The following is a description of a gene set: studied in species Mus musculus from publication Yevshin I, Sharipov R, Kolmykov S, Kondrakhin Y, Kolpakov F (PMID 30445619) Genes containing one or more binding sites for (Myb) in their promoter regions (TSS -1000,+100 bp) as identified by GTRD version 20.06 ChIP-seq harmonization. Mouse Gene Set: MYB_TARGET_GENES, and this is the list of marker genes: Ccdc15, Smarcc2, Cc2d1a, Usp11, Usp36, Arf6, Septin9, P2rx4, Tspo2, Asphd1, B230369F24Rik, Epb41l4aos, Rbfox2, U2surp, Katnal1, Cdc123, Atp2b4, Tax1bp1, Nelfa, Depdc1b, Trem1, Yif1b, Pigc, Rhobtb1, Tmem143, Eri3, Cep83os, Yars1, Gm15518, Wdfy2, Heg1, 4933406C10Rik, Cep70, Tmem33, Mblac1, B4galnt1, Tnfaip6 (tumor necrosis factor alpha induced protein 6), Sae1, Mrps23, Sf3a3, Taf5l, Gm22353, Il3ra, D030047H15Rik, Aldh6a1, Cacna1c, Rrm1, Kcnq1, Cep97, Pdcd5, 1700034P13Rik, Ifitm7, Cct8, Ambra1, Lrrc40, Cd69, Snord15a, Dhrs7b, Gnaq, Eprs1, Cspp1, Sema6b, Rbp2, Tti2, Zfp87, Mutyh, Cmtr1, Ep400, Cebpa, Psmb3, Raf1, Ptgs1, Gm25408, Ubn2, Slc35e1 (NCBI Gene Id 270066), Cdan1, Anapc10, Psma6, Emc3, Gm15581, Sms, Mllt3, Syngr4, Gm11532, Nme7, Map2k5, Tbl3, Abcf2, Nol8, Pex12, Golt1b, Clcn3, Gm8197, Toe1, Zfp35, Prps1l1, Pigv, Sh3gl1, Slc28a2, Pip4k2a, Tubgcp6 (NCBI Gene Id 328580), Acsl6, Fam117a, Gm16023, Tardbp, Tesmin, Znrf1, Hexim1, Rfx2, Cnot1, Tbl1xr1, Nab2, Treml4, Wdr7, Borcs8, 4833445I07Rik, Hes6, Tspyl3, Gm28857, Gm15564, Ccdc14, Cope, Zfp560, Trem3, Kif2c, Chrm3, Maz, Mir3074-2, Spag5, Shoc2, Nphp1, Fam118a, Ttbk2, Gm20257, Adipor2, Ash2l, Thoc6, Pbx4, Dtx4, Arhgef10l, Amz2, 5530601H04Rik, Trap1 (TNF receptor-associated protein 1), Sod2, Txnip (thioredoxin interacting protein), Gm33280, Mcpt8, Fkbp7, Ywhaz, Akirin1, Aff1, Mrps18c, Pkd1l2, 4930558K02Rik, Rnf44, B230217O12Rik, 4930532G15Rik, Hnrnpa2b1, Stab1, Gse1, Cd81, Snx17, Ptk2b, Dcbld2, Kctd7, Lcp1 (lymphocyte cytosolic protein 1), Ezh2, Cldn15, Rgl2, Ripor1, Dhtkd1, Mlst8, Trpm2, Entpd5, Cntrob, Asrgl1, St7l, Hdac7, Tmed5, Mir7008, H2ax, Brme1, Hmgxb3, Taf9, Gm4035, 4933439C10Rik, Cep78, Pyroxd2, Acot8, 5730455P16Rik, Mapkapk5, Dctn4, Farsa, Cox19, 5930430L01Rik, Tnfrsf14, Spns3, Arhgap45, Tfec, Ccdc88a, Zmiz2, Dock10, Phf7, Cnot7, 4732440D04Rik, Nsun2, Bbof1 (NCBI Gene Id 72873), Dguok, Gm10064, Coq9, Med20, Add1, Mtrfr, Gm7158, Prdm10, Man1b1, Mir27a, Tmem126a, Gm14455, Msl2, Sdccag8, B4galt7, Piga, Adcy7, Odad1, Pvt1, Sez6l2, Elmo1, Pcgf5, Cdca2, Lmna, Hoxa7, Hnrnpul2, Tbc1d17, Ppp6r3, Mir5133, 1700047K16Rik, Dazap2, Sgo2a, Ptrhd1, Zbtb9, Pnkd, Camkk2, Snrnp35, Uqcc4, Nucb1, Usp5, Gm13470, 2310001H17Rik, Med7, 9430015G10Rik, Slc7a11, Cyb561d2, Morf4l1, Coa5, Htra2, Tle6, Dlgap5, Hsp90aa1, Agtpbp1, Nudt13, Tgfbrap1, Kdm5c, Gm19721, Psma1, Ccl9, Atg2a, Ddx49, Tcp1, Car1, Mrpl39, Tfrc, Gm16069, Calr, Glb1l, Frat2, Wdr36, Tbp, A230072C01Rik, Zfp207, Kat14, Ccnk, Atrip (NCBI Gene Id 78099), Glipr1, Pate2, Pdap1, Mrpl4, Taco1, Atp6v0b, Ifrd2, Asb1, Rlf, Zcwpw2, Nmbr, Lrp4, Dus1l, Ubxn4, Epo, Cenpo, Nup50, Acbd3, Taf3, Kif20a, Pla2g12a, Gna11, Snhg20, Tmem229b, Tada3, Slc25a28, Ssx2ip, Cntd1, Mmachc (NCBI Gene Id 67096), 4930456G14Rik, Fam227b, Zfp956 (zinc finger protein 956), Cask, G6pc3, Snord49b, R3hcc1l, Gm11335, Ptgr1, Itga4, Asb15, Nrros, Acyp1, Cd300lb, Gm42579, Anapc1, Creb1, Cdkn2aip, Nr2c2, Vgll4, Nfe2l2, Ifnar2, Ro60, Pum3, Styk1 (serine/threonine/tyrosine kinase 1), Fbxw5, Kdm4d, Zcchc8, Cep57l1, Cenpu, Senp2, Inpp5a, Echs1, Trmt44, Pik3ca, Spg7, Cenpp, Tmem109, Chmp4b (NCBI Gene Id 96954), Epn1, Mettl6, Ulk2, Fbxl12, Lin52, Dock8, Crtc3 (NCBI Gene Id 70461), Bcap31, Edc4, Ube4a, Fbxo24, Ddx39a, Kctd9, Rem2, Il4i1, Dnajc11, Ttc9c, Pias1, Yipf2, Glce, Gys1, Sec24a, Dph3, Rmnd1, Hjurp, Spag9, Zdhhc4, Ocel1, Tmbim4, Dtwd1, Lmo2, Mir24-2, Erlin2, Fastkd5, Prss36, Gm23454 (NCBI Gene Id 115489208), Sdhaf4, Hps4, Cyb5d2, Wdr74, Znrf2, 4930426L09Rik, Trmt13, Snai3, Aebp2, Slc66a3, Ctu2, Ptges3, Lig3 (ligase III, DNA, ATP-dependent), Stk19, Arf4, Fmc1, Rsrp1, Airim, Phrf1, Snrpc, Rps3, Cyth4, H3f3b, Eaf1, Polr1has, Trbv1, Helq, Mir3103 (microRNA 3103), Ccdc117, 0610012D04Rik, Nmt1 (NCBI Gene Id 18107), Gm7461, Irs2, Utp18, Smarcal1, Evi2b, Arid1a, Pecam1, Mapk14, Cdca3, Dusp23, Slc38a9, Mipepos, Rbm33, Ctsg, Gbf1, Cdadc1, Gna15, Cyren, Mtarc1, Prdm15, Psmd5, Pus10, Pou6f1, H4c14, Strbp, Abcb4, Rexo5, Hnrnpa1, Ino80 (NCBI Gene Id 76476), Aptx (aprataxin), Tex2, Cox7c, Tnnt2, Siah1a, Rnf19a, Zfp382, Ermap, Tasl, Cachd1, Cx3cr1, Psip1, Cluh, Zfp263, Sdad1 (SDA1 domain containing 1), Rfxank, Polr1h, Dgat1, Gnai3, Xpo5, Pet117, Sprtn, Gm27011 (NCBI Gene Id 115486886), Khk, Serinc3, Pkig, Sugct, Abhd14b, Pkd1l3, Armt1, Wbp2 (NCBI Gene Id 22378), Steep1, Gm10287, St7, Etfa, Sppl3, Luc7l, Calm3, Arhgap15, Leng8, H4c8, Map1lc3b, Snrpd3, Morn1, 4930432B10Rik (RIKEN cDNA 4930432B10 gene), Gle1, Bud31, Dnaaf9, Rabgef1, Becn1, 0610030E20Rik, Meig1, Magohb, Ccar2, Zfpl1, Gm11635, Tnfaip2, Raver1, Adss1, 0610040B10Rik, Pef1, Atp8b3, Med24, Mst1r, Prcc (papillary renal cell carcinoma (translocation-associated)), Csnk1g2, Odf2l, Ift80, Uhrf2, Erlin1, Emc9, Gspt1, Id1, Golga2, Acad9, Fcho1, Cbx5, Neurl3, Pradc1, Clip1, Dpy19l1, Hspa4l, Fam53c, Gm6209, Tlnrd1, Anln, Ccl27a, Ercc2 (excision repair cross-complementing rodent repair deficiency, complementation group 2), Ilf3, Mis18bp1, Arhgap33, Eftud2, Cdc20, Ranbp10, Arhgap11a, Lpin2, Ppp2r5c, Dgkg, Dph7, Gm23502, Gm12984, Phf5a, Mir5627, Ifrd1, Cstf1, Rpl21, Atf7ip, Ccl6 (NCBI Gene Id 20305), Abcb8, Gm1110, Ssbp1, Trpm8, Unk, Wiz, Pex13, Nrip1, Gm11423 (NCBI Gene Id 100503272), Mir6516, Ndufa5, Dctn5, Ndst3, Rnf7, Acmsd, Pdss1, Dazap1, Fam169a, Gdf9, Spmip2, Fdxr, Snx3, Atf5, Slc28a2b, Mrpl20, B9d2, Cpa3, Rnf187, Pomgnt1, Hyls1, Fam216a, Cwc25, Rnu11, Rpl29, Cpq, Nop14, Zfp330, Thumpd3, Gba1, Txndc17, Dtymk, Pfkp, Ubl5, Fth1, Rsrc2, Oxsm, Zgrf1, Gatc, Zfyve1, Mbnl1, Rassf1, Fancd2, Rnf139, Prkab1, Cand1, Snx18 (sorting nexin 18), Rrp1, Zfp652, Nck2, Tssc4, Atp7b, Cdc26, Gmds, Ppp4r3b, Fbxo30 (NCBI Gene Id 71865), Gm9484, Blmh (bleomycin hydrolase), Ropn1l, Trim16, Abcd1, Large2, Ranbp2, Dusp3, Pxylp1, L3mbtl2, Dnaaf10, Ubap2, Tlcd1, Gm2a, Galnt11, Tonsl, Rps18, Tmem230, Uba7, Ntng2, Cks2, Mitd1 (MIT, microtubule interacting and transport, domain containing 1), Ccdc186, Gm5833, AV039307, Ppp1cc, Foxp1, Cd248, Blzf1, 1700023C21Rik, Vps72, Gal3st2b, Lsm5, Cenpv, Eapp, Cfap298, Mgst1, Zfp367, Rps6kb2, Vcpip1, Gzf1, Ciapin1, Dis3l2, Mir707, Cytip, Supv3l1, Cnot6, Gata1, Nudt19, 3110031N09Rik, Cdca8, 4930404I05Rik, Icam2, Tdg-ps2, Ermp1, Nek2, Snord13, Pigq, Ado, Luc7l2 (NCBI Gene Id 75005), Kbtbd6, Cltc, Slc40a1, Taf1a, Snx1, Tbc1d31, Eif4e, Elf2, Gm6373, Atxn1l, Spcs1, Zfp668, Mir7688, Ddx47, 4933406I18Rik (NCBI Gene Id 71045), 4933437G19Rik, Rpl22 (ribosomal protein L22, NCBI Gene Id 67183), Aurka, Cass4, Gm38250, Neil1, Mkks, Akip1, Rin3, Rapgef1, Rptor, Gtf2h3, Ttll13, Rcsd1 (NCBI Gene Id 77931), Coa6, B230317F23Rik, Slc25a3, Ngly1, B130034C11Rik, Txlng, Ubxn11, Plec, Cd300c, Msl3, Sephs2, Rer1, Kel, Pkn3, Anp32e, Astl, Eif4a3, Frmd8os, Chaserr, Rffl, Plg, Gm23639, Pbld2, Sub1, Rad17, P2rx3, Crnde, Gnb2, Wdr25, Slc23a2, Gm22830, Ggnbp1, Isca1, Tfr2, Mcrs1, Hormad2, Arpc4, Gm13778, Gfpt1, Cops7b, Stat3, 2310034G01Rik, Nicn1, Akt2, Rps15, Osbpl9, Mir7036b, Heatr5a, Golga7, Mir1956, Klhdc4, Tmem242, Arsk, Ssh2, Abhd14a, Tnpo3, Appl2, Eda, 1700017B05Rik, Knstrn, Gale, Atf1, Nsmce4a, Gm14023, Poc1a, Gtf3c6, Scp2, Rsrc1, Ddx31, Enkd1, Hif3a, Gm20517, Etohd2, Ccp110 (centriolar coiled coil protein 110), Ndufs7, D16Ertd472e, Ubr4, 4933427D14Rik, Pafah2, Gnat2, Mul1, Vps13d, Cggbp1, Adamts3, Arhgap25, Ttc39d, 1600010M07Rik, Kdm2b, Chd2, Fam120b, Kcnq3, 1700113A16Rik, Tsnaxip1, Rpl8, Gpalpp1, Gm11520, Rpl6l, Gm25008 (NCBI Gene Id 115488875), Ppp4r3a, Zfp598, Haus3, Cttnbp2, Zc3h13, Znrd2, Prpf19, Aldh3b1, Lamp1, Sumf2, Txndc11, Atxn7l1, Wapl, Zfp91, Cnot6l, Trp53rkb, Ptpn7, Fnip1, Arl6ip1, Skic3, Chd6, Rusf1, Ndufb5, Neat1, Iqsec1, Inmt, Pheta1, Stam, Ndufs2, Trappc1, Rpa3, Snord68, Taf6l, Ap2m1, Zscan22, Naa25, 1810008I18Rik, Gna12 (guanine nucleotide binding protein, alpha 12), Lipn, Smim24, Spns2, Cpsf4, Gm13524, Cdca5, Tcea1, Pxn, Caap1, Hes2, Cyth1, Cerkl, 4930558J18Rik, Pomt1, Pabpc1, Pno1, Rps9, Exoc2, Sertad1, Slc26a1, Tmed2, Ctse, Psmb2, Chmp2a, Thrap3, Cox20 (NCBI Gene Id 66359), Wdpcp, Olr1, Psmd3, Gm22620, AY702103, Tmem186, Fcgr2b, Nsd3, Dnajb9, 4930520O04Rik, Gm28809, Ttc7, Trp53, Bcl2l12, Bicd2, Pbdc1, Mir223hg, Usp48, Hnrnpu, Hcfc1r1, H4c16, Tcirg1, Ckap5, Cfap43, Prdm4, Zfp646, C87436, Rbm5, Slx4ip, 1500026H17Rik, Rnpep, Tbc1d25, Lhfpl2, Rmdn3, Hnrnpa0, Gne, Cep83, Vezt (vezatin, adherens junctions transmembrane protein), Cdkn2d, Nfe2, Ccdc97, Itgb5, Igkv10-95, Zswim3, Tut1, Aasdh, Cercam, Gm23205 (predicted gene, 23205), Unc50, Pabir2, Setd3, Cuta, Pex1, 4930403D09Rik, Taf2, Gtf2h1 (general transcription factor II H, polypeptide 1), Tob1, Gpam, Ift20, Nfx1, Cbx3 (NCBI Gene Id 12417), Vta1 (vesicle (multivesicular body) trafficking 1), U2af2 (U2 small nuclear ribonucleoprotein auxiliary factor (U2AF) 2), Rab27a, Zfp617, Dctn6, Gm20605, 4933406P04Rik, Gm4117, Nwd1, Acot7, Dlgap4, Rbm14, Nmnat3, 1110002L01Rik, Bach2os, Wipf2, Smad3, Mlx, Eri2, Pex10, Tsc22d4, 4931440P22Rik, Ap1m1, Zbtb49, Kcne3, Mir191, Il1rl1, Ndufaf7, Smim11, Arl2, Med26, Piezo1, Cebpz, 5730460C07Rik, Tial1, Ddost, Gm7189, Kat7, Gm25791, Dhx8, Kif2a, Gm26611, Psmd8 (proteasome (prosome, macropain) 26S subunit, non-ATPase, 8), Gm24357, Ccdc63, Mir8120, Oxnad1, Ccdc163, Ap1b1, Spata13, Mirt1, Prrc2a, Gm12311, S100a8, Anapc2, Wwox, Plod3, Vapa, Josd1, Uqcrq, Larp7, Ciart, Tcf3 (transcription factor 3), Cpox, Map2k7, Mbtd1, Marchf3, Thoc7, Popdc2 (NCBI Gene Id 64082), Zfp54, Pex16, Mxi1, Mrpl30, Bmp2k, Rbmx, Btbd9 (NCBI Gene Id 69375), Wbp4, Ankrd12, Vmn1r4, Slc12a6, Srd5a1, Dap3, Cfap418, Tiprl, Ercc6, Tnip3, Sar1b, Slc4a2, Trerf1, Capzb, Cnep1r1, Dnaja3, Pgk1, Birc2, Slc43a2, Coa3, Arel1, Nup153, Grk4, C330013E15Rik, Sypl1, Arih2, Rbsn, Cwc15, Tasp1, Retreg2, Usp6nl, Slc25a39, Tmem115, Gm7785, Rpl27, Slc36a2, Calm2, Ccdc18, Rnf20, Trmt112, Npdc1, Klhl23, Mettl25, Nkapl, Srrd, Sde2, Rfx5 (NCBI Gene Id 53970), Stk10, Caprin1, 1700120C14Rik, Bbip1, Mrtfa, Ino80b, Snrpa1, Cog1 (component of oligomeric golgi complex 1), Uqcc1, Prss22, Snrpb2, Clk3, Gtse1, Mrpl2, Ftsj1, Nemp1, 6530402F18Rik, Gmfg, Nlrp3, Mdh1, Armc6, Ptprc, Mtln, Urb2, Gm17435, Pcp4l1, Sowahc, Pmm2, Pknox1, Cbll1, Nav2, Drg2, Ppm1g, Dpp9, Amdhd2, Cyp4v3, C2cd5, Cep170, Rrp1b, Bbs9, Susd3, Garin5a, Dffb, Spty2d1, Swi5, 1700123O20Rik, Gm14453, Sgms1, Cep76, Hdgf, Slc39a3, Ints7, 2610035D17Rik, Ube2t, Cdc37l1, 2410006H16Rik, Myct1, Trmt61b, Atad5, Tmem260, Myl6b, AI597479, Yy1, Rab11b, Zmym6 (zinc finger, MYM-type 6), Aamp, H2bc26, Numb, Atg101, Cpsf1 (cleavage and polyadenylation specific factor 1), Nup133, Utp3, Ptpa, Rpl18, Gm21992, Dnajc27, Snd1, Dusp6, Psmg2 (proteasome (prosome, macropain) assembly chaperone 2), Tmx4, Prss57, Dynlt2b, Duxf1, Tmem167b, Cox18, A730089K16Rik, Gm25703, Gucd1, Elane, Mplkip, Hnrnph1, Zbed4, Wars1, Ncln, Mcub, Ptbp1, Aco2, Nufip1, Lrwd1, Zfp740, Gm5447, Tcf4, Nploc4, Tmem107, Gcnt1, Spop, Add2, Cenpc1, Pigu, Znhit1, Zmat1, Bdp1, Pklr, Trappc14, Lrch4, Naxe, Plekhg2, Wdr62, Paip2, Tacc1 (transforming, acidic coiled-coil containing protein 1), Rpl13, Slc14a1, Golga1, Clcn6, Zbtb5, Tmem222, Mphosph9, Kmt2a, Ssna1, Tmt1a, Lrmda, Malat1, Efcab9, Opa3 (optic atrophy 3), Clec12a (NCBI Gene Id 232413), Mefv, Maml1, Isg20, Guf1, A930006K02Rik, Ccz1, Dgkz, Tfb1m, C8g, Smc4, Tent5d, Chmp1b2, Gm21985, Fbxo28 (F-box protein 28), Trub1, Zc3h7a, Gga1, Haus5, Ndst2, Mthfr, Palb2, Tbc1d22b, Ndufaf3, Tcam1, Atp5f1b, Mfn2, Stk40, Gm36307, Banp, Smg6, Syde2, Mir8098, Gtf2f1, Azi2, Rb1cc1, Gm5420, Gm12279, Rdh11, Brdt, Cnppd1 (cyclin Pas1/PHO80 domain containing 1), Mbtps2, Cdk11b, Tinf2, Gm25541, Zbtb20, Irf3, Gm15559, Dmwd (dystrophia myotonica-containing WD repeat motif), Dcakd, Hspb9, Tcaim, Ptp4a1, Zfp566 (zinc finger protein 566), Pparg, Dut, Ddx3x, Mrpl18, Gm15441, Gin1, Gm15926, C130060C02Rik, Vdac2, Mir6236, Vps52, Tchp, Tmem185a, Aqp9, Tspyl1, Tgfbr3, Dhrs3, Gpr174, Zfp882, Snord3a, Ppp1r35, Vim, Nxt2, Znhit3, Lyar, Ddit3, Nup214, Clptm1l, Sugp2, Bysl (NCBI Gene Id 53955), Pop4, Adprs, Taok3, Lnpep, Uxt, Chct1 (CHD1 helical C-terminal domain containing 1), Arid2, Tagln2, Zdhhc18, Mzt1, Triobp, Glcci1 (NCBI Gene Id 76466), Entrep3, Rnf166, Dars2, Zfp1, Prpf4, Ak6, Utp15, Ksr1, Dpy19l4 (NCBI Gene Id 93698), Exoc8, Smpd4, Xpo6, Fam107b, Pde3b, Mpzl2, Frrs1, Rad52, Polr2a, Srfbp1, Eif2b1 (eukaryotic translation initiation factor 2B, subunit alpha), Mrrf, Cep85, Usp32, Setd5, 5430405H02Rik, Rps6ka1, Bap1, Hps5, Setx, Polg, Gm6410, Gorasp2, Mark2, Slc15a3, Alkbh4, Rbm39, Get1, Qsox1, Mrpl24, Cenpl, Ciao2a, Mir1945, Slc25a21, Dolk, C2cd3, 1700064H15Rik, Gm11633, Mlkl, Armc8, Glrp1, Golga7b, Upf1, Fut7, Angptl8, Meiob, Mrps17, Psmc3, Gm16316, Lrrc66, Nprl2, Snord49a, Rcor1, Arhgap32, Ndufa10, Cep135, Ndufv1, Nxt1, Agrn, Gm24233, Naa15, Gins1, Ubl4a, Bpnt2, Cage1, 4930405A21Rik, Xrn2, Ccdc59, Mrpl52, Mir23a, Rasgrp2, Tmem250, Manbal, Kdm8, Mfsd11, Iba57, Taf1c, Bloc1s5, Snord118, Rbm48, Milr1, Ppan, Prkci, Khdc4, Phf12, Slc39a11, Tfip11, Gm22341, Smim10l1, Ralbp1, Wdr45b, 2410002F23Rik, Sf3b1, Dnajc10, Stk16, Ap2b1, Mir8105, Gm13421 (NCBI Gene Id 105244102), Wrap53, Dapp1, Arhgdib, Fam110a, Zbed3, Trim59, Coq10a, Platr26, Zfp672, Zbtb44, Six4, Cdk5, Aup1, Tnfaip1, Abce1, Nme1, Mbd1, Gclm (glutamate-cysteine ligase, modifier subunit), A430035B10Rik, Rnf169, Gm6116, Utp4, Ndufa9, Ccdc103, Triap1 (TP53 regulated inhibitor of apoptosis 1), Katna1, Ddb1, Kdm2a, Lat2, Brd8, Dnajb1, Uchl5, Aftph, Fos, B230219D22Rik, Thbs4, Gm24992, Tgif1, Trim56, Prr14, Alg9, Ash1l, 1700029J03Rik, Ubb (NCBI Gene Id 22187), Hapstr1, Tbl2, Hspa5, Ank3, Mpi, Eif2b4, Mrpl58, Atg9b, Stn1, Hmgb2, Eif2ak2, Brf2, Wdr37, Rad54l, Zzef1, Dxo, Gpn3, Polh, 1700066M21Rik, Gm12711, Egln2, Akt1s1, Ccdc61, Steap3, Slc41a3, Dclk2, C130050O18Rik, Atp5po, Sema3c, Mta2, Gm15493, Ywhah, Tm9sf3, Gm16322, Hk1, Klhl15, Nat10, Sphk2, Cep20, Nup188, Poln, Poc5, Gm20658, 4933404O12Rik, Hnrnph3, Esyt2, Abhd11, Spire2, Chtf8, Phf6, Fbxo34, Ubox5, Ubash3b, S100pbp, Slco3a1, Adgrg3, Mrps15, Art4, Cep104, Retreg1, 1810064F22Rik, Sesn1, Atxn2l, Nfia, Ccdc57, Stmn1, Aasdhppt, 1810044D09Rik, Nsfl1c, Srsf2, Ckap2l, Jmjd1c, Ap1g1 (NCBI Gene Id 52301), Gpbp1l1, Spag6l, Supt20, Mir744, Atp6v0d1, Mir1901, Asxl2, Ddc, Lmbr1l (limb region 1 like), Vamp4, Ptcd1, 4930513N10Rik, Bcr, Ndufs5, Eif2b3, 4930519L02Rik, Rab7b, Diablo, Pigk, Gm10750, Klf1, Atp5mc2, Slpi, Urm1, 9330159M07Rik, Prdx5, Tmigd3 (transmembrane and immunoglobulin domain containing 3, NCBI Gene Id 69296), 4933405L10Rik, Mnt, Iffo1, Mlec, Ptprv, Gmfb, Srsf11, Tespa1, Dph1, Mipep, Adam3, Map2k1, Ccdc158, Emc10, Samd13, Gm13610, Mylk3, Mat2b, Ctnna3, Snx32, Nuf2, Ube2j2, Fhip2a, Gm4734, Crat, Alg11, Snx27, Hnrnpll